Given this list of marker genes ACOX1, ABCD3, ABCD1, ABCD4, SLC27A4, SLC27A2, ABCD2, here is a description of the gene set: Human Gene Set: GOBP_VERY_LONG_CHAIN_FATTY_ACID_CATABOLIC_PROCESS studied in species Homo sapiens The chemical reactions and pathways resulting in the breakdown of a very long-chain fatty acid. A very long-chain fatty acid has an aliphatic tail containing more than 22 carbons.